The following is a description of a gene set: species: Homo sapiens Human Gene Set: chr16p11, and this is the list of marker genes: ZNF688 (zinc finger protein 688), ITGAL-AS1, CORO1A-AS1, TP53TG3GP, RNA5SP406, TUFM, SLC5A2, RARRES2P10, ZNF646, RUSF1-DT, ENPP7P13, RN7SKP127, SETD1A, CHEK2P6, HIRIP3, RNA5SP413, KRBOX5, FUS, CDIPT, PRSS8, BCLAF1P2, FAM153DP, SEZ6L2, LAT, QPRT, ZNF48, MAZ, IGHV3OR16-6, AGGF1P6, TP53TG3E, VN1R67P (NCBI Gene Id 100131118), RBM22P13, ZNF768, PPP4C, RNA5SP415, TMEM219, KRBOX5P1, RARRES2P9, VN1R66P, SMG1P6, RNA5SP420, SGF29, RNA5SP410, NFATC2IP, C2orf69P2, BOLA2-SMG1P6, PLA2G10CP, TMEM265, NAMPTP3, ABHD17AP9, STX4, CDC37P1, RNA5SP423, KCTD13, TLCD3B, NPIPB11, BOLA2B, VN1R64P, ABCD1P3, CD19, ITGAM (NCBI Gene Id 3684), MYL11, NDUFA3P6, SLC6A10P, IGHV1OR16-4, COX6A2, C16orf54, IGHV1OR16-2, ZG16, MVP, MIR762HG, FBXL19, SNORA80C, BCKDK, ZNF785, RNA5SP419, LINC02190, INO80E, RNA5SP417, PLA2G10JP, SLX1A-SULT1A3, ARMC5, RRN3P2, PLA2G10KP, HERC2P8, HSD3B7, DOC2A, PYDC1, ASPHD1, ZNF689, CLUHP3, NPIPB8, TP53TG3F, HERC2P4, FRG2HP, CTF2P, BCL7C, KIF18BP1 (NCBI Gene Id 642683), SLX1A, CA5AP1, RNF40, RNU7-61P, IGHV3OR16-12, BOLA2 (NCBI Gene Id 552900), SPNS1, RNA5SP408, AGGF1P9, MIR6862-2, ATXN2L, IGHV3OR16-17, SULT1A1, IGHV2OR16-5, RARRES2P5, SNORA30, RNA5SP416, MIR4518, RNA5SP418 (NCBI Gene Id 100873669), HMGN2P41, IGHV3OR16-9, RARRES2P8 (retinoic acid receptor responder 2 pseudogene 8), ENSG00000261840, ITGAL, LINC02184, SNX29P2, LINC00273, C16orf92, PYCARD, SLC7A5P1, ATP2A1, CCNYL3, FGFR3P5, MAPK3, SLX1B-SULT1A4, IGHV3OR16-11, SMG1P5, ZNF764, ZNF843, TBX6, IGHV3OR16-8, ZNF747-DT, CHEK2P7 (CHEK2 pseudogene 7), ACTR3BP3, CLUHP11, PABPC1P13, BCAP31P1, ZNF971P, BCAP31P2, VN1R65P, RBM22P12, SMG1P2, NFATC2IP-AS1, KIF22, TP53TG3B, ABHD17AP8, VN1R3, FBRS, RNA5-8SP2, VN1R68P, CORO1A, CD2BP2-DT, C2orf69P3, CFAP119, SRCAP, LINC01566, AGGF1P5, FRG2JP, MIR3680-2, FRG2DP, PAGR1, UBE2MP1, CD2BP2, IGHV3OR16-10, ZNF629, PPP1R1AP2, DUX4L46, AGGF1P7, PRSS53, VKORC1, ZNF747, NPIPB10P, RNA5SP422, FRG2KP, MIR4517, AGGF1P4, IGHV3OR16-13, STX1B, ENSG00000259807, VPS35P1, MIR4721, KAT8, C1QL1P1, TP53TG3D, ENSG00000273582, ENSG00000261398, C2orf69P1, KCTD13-DT (KCTD13 divergent transcript), RUSF1, IL27, RABEP2, AHSP, PRRT2, TAOK2, DUX4L47, TRIM72, ALDOA, LINC02167, RNU6-416P (RNA, U6 small nuclear 416, pseudogene), TP53TG3C, TP53TG3, SLC25A1P4, FRG2GP, PHKG2 (phosphorylase kinase catalytic subunit gamma 2), SEPHS2, HERC2P5 (NCBI Gene Id 8919), IGHV3OR16-16, RNA5SP421, MIR4519, CCNYL1B, YPEL3, ENSG00000260958, RPL7L1P16, ITGAD, C2orf69P4 (chromosome 2 open reading frame 69 pseudogene 4), ATP2A1-AS1, VN1R70P, ZNF267, NPIPB9, PLA2G10DP, RNA5SP414 (RNA, 5S ribosomal pseudogene 414), RNA5SP411, PYCARD-AS1, IGHV1OR16-3, RARRES2P6, PLA2G10HP, RNA5SP409, RARRES2P7 (retinoic acid receptor responder 2 pseudogene 7), EIF3C, NPIPB13, NPIPB12, RNA5SP407, SULT1A2, ENSG00000285043, ENSG00000290677, GDPD3, TBC1D10B, YPEL3-DT, ENSG00000296833, FRG2IP, YBX3P1, MVP-DT, ARHGAP23P1, SULT1A4, MIR762, AGGF1P8, IGHV3OR16-15, PRSS36, ENSG00000295790, ZNF668, PRR14, DUX4L45, CTF1, TP53TG3HP, NUPR1, SULT1A3, SEPTIN1, ITGAX, IGHV3OR16-7, VN1R69P, ORAI3, PCMTD1P2, DCTPP1, BMS1P8, SH2B1, ABHD17AP7 (ABHD17A pseudogene 7), SPN (sialophorin), FBXL19-AS1, RNA5SP412, RNU6-1043P, TGFB1I1, SLX1B, CDIPTOSP, ZNF771, IGHV1OR16-1, ENSG00000293342